Given this list of marker genes Rab6a, Tbc1d10c, Tsc2, Rab11b, Tsc1, Tbc1d16, Map1lc3b, Tbc1d24, Rab33b, Rab8a, Tbc1d15, Tbc1d13, Gabarap (gamma-aminobutyric acid receptor associated protein), Rab11a, Sytl1, Tbc1d17, Ulk1, Arf6, Tbc1d14, Tbc1d25, Rabgap1, Optn, Rab33a (RAB33A, member RAS oncogene family), Rab7, Gabarapl2, Rab6b, Tbc1d7, Tbc1d10b, Rab35, Rab4a, Rab7b, Tbc1d10a, Rab8b, Tbc1d2, here is a description of the gene set: Mouse Gene Set: REACTOME_TBC_RABGAPS TBC/RABGAPs species: Mus musculus